Given this list of marker genes RSBN1, POU2F3, ACOT9, ZBP1, TNFSF8, NRBP1, DBNL, FERD3L, TMEM70, CACUL1, CDH4, DOK1, COL3A1, SH3BGRL2, VOPP1, CDK14, DUSP26, RANBP1, WNT7A, EVA1A, FBXO42, RBM26, CHMP6, AKT3, ARID4B, HMGN3, PLAT, HGF, IFT172, RABEP2, DUSP2, GAS7, RAB3IP, RSPRY1, LHX2, PKP4, SERPINB1, H2BC18, NFKB2, POLE3, FAM53C, TBL1X, GTF2F1, SLC12A6, APPL1, OTUD7B, PRPF38A, MAGIX, SLC46A1, NTS, SLC10A1, IQSEC1 (NCBI Gene Id 9922), DTX1, RTCA, GTPBP1, RAB32, UBE2H, ISG20 (NCBI Gene Id 3669), PCDHA11, ACADL (acyl-CoA dehydrogenase long chain), TRIM21, RARS1, ATL3, ALDH1A2, USP43, CCRL2, FGF13 (fibroblast growth factor 13), STX3, FAM110C, CCR4, IFIH1, HOXC13, FMR1, STK39 (NCBI Gene Id 27347), PFKP, FYN, MAFK, PHACTR2, SAMHD1, ERCC3, MAP3K11, KLRK1, STXBP1, BRAP, MOV10, ILF3, CST11 (NCBI Gene Id 164378), CPPED1, TSPYL1, CLMP, FNBP4, PCNA, DOK3, PIGN, IRF1, TBC1D13, LRRC8C, FICD, SAR1A, HSPA1B, TIMP1, IFI35, RAP2C, GJD2, ARG2, RBL1, TBX4, ZNF574, SEC24B, SNRK, TLCD2, BFAR, POU3F1, CD164, PLCB4, RAB30, SNX10, TNFAIP1, TMEM219, ARHGAP20, PPM1A, ACVR1, ELOC, SP6, SMAD2, ZBTB14, CRY1, KCNN2, H2AZ1 (H2A.Z variant histone 1), RDH10, FLNB, UGDH, MAD2L1, ARL4A, MEP1A, RCN1, DBNDD1, MXI1, RTRAF, KLRD1, DNAJB1, DCX, PRKD2, MAP2K3, ADPRH, ASCL3, RILPL2, CAPN6, STK4, LPCAT3, PHLDB1, SUGT1, STARD8, BRD2, SFMBT2, OSBPL10, CA2, DCBLD2, IDH3G, RASA1, CACYBP, TGM2, CDKN1B, PABIR1, PTGS2, GPR85, BMI1, TNFSF9, PCNX1, FUT2, VRK1, RBMS2, HLA-G, UBE2D1, ITGAV, SPECC1, PI4K2A, SSBP2, RAB9A, NACC1, IL36A, LY96, ATM, NCKAP1, PHTF1 (putative homeodomain transcription factor 1), IGBP1, FURIN, ZFX, PDCD10, HK1, ATP10A, WARS1, RDH11, GNA13, RHBG, CALCR, ATP11B, CYP24A1, PMPCB, HERPUD2, here is a description of the gene set: Human Gene Set: GSE17721_LPS_VS_CPG_6H_BMDC_UP studied in species Homo sapiens from publication Amit I, Garber M, Chevrier N, Leite AP, Donner Y, Eisenhaure T, Guttman M, Grenier JK, Li W, Zuk O, Schubert LA, Birditt B, Shay T, Goren A, Zhang X, Smith Z, Deering R, McDonald RC, Cabili M, Bernstein BE, Rinn JL, Meissner A, Root DE, Hacohen N, Regev A (PMID 19729616) Genes up-regulated in comparison of dendritic cells (DC) stimulated with LPS (TLR4 agonist) at 6 h versus DC cells stimulated with CpG DNA (TLR9 agonist) at 6 h. mouse primary BMDCs were stimulated with tlr ligands and gene expression changes were profiled on Affymetrix arrays